Given this list of marker genes Nfatc1, Zfp980, Rnf34, Gsn, Grb2, Mapk14, Kcmf1, Mdh1, Rad51d, Gosr2, Nfat5, Acap2, Elovl2, Taok3, Acat3, Zfp367, Nploc4, Zdhhc17, Rex2, Mex3b, Elovl7, Rev3l, Ppm1d, Luc7l3, Vps50, Pbdc1, Zc3h4, Hoxb1, Cfap97, Ube2b, Prkci, Upp2, Tmtc1, Dram1, Far1, Ctxn1, Nkain2, Zfp513, Dcaf17, Sec61a2, Mnat1, Kras (Kirsten rat sarcoma viral oncogene homolog), Zfp112, Vcpip1, Zbtb34, Pou6f1, Arfgef1, Robo2, Stim1, Osbpl7, Rffl, Rrbp1, Pnpla2, Zfp600, Uchl5, Map2k6, Ark2n (NCBI Gene Id 212163), Scart2, Robo1, Abi1, Ankle2, Ostn, Yeats2, Itm2c, Trem1, Gria3, Ccnk, Snap91, Atf5, Sntg1, Tmem43, Clrn1, Homer1, Epha7 (NCBI Gene Id 13841), Tspoap1, Ctdspl2 (NCBI Gene Id 51895), Rnf139, Msc, Rdx, Zfp981, Mfsd4b1, Dlgap1 (NCBI Gene Id 71192), Crk, Gls2, Osbpl6, Ctbp2, Tmem52b (transmembrane protein 52B), Papolg, Ankrd29, Brdt, Aqp4, Edrf1, Slc14a1, Prl, C8b, Csmd3, Pip5k1c, Wdr72, Hpca, Gpcpd1, Tmem104 (transmembrane protein 104), Ano4, Wdr1, Klhl14, Fam241a, Gsk3b, Mmd, Zbtb11, Mrpl1, Ptgr1, Acat2, Jmjd1c, Herpud2, Tnfrsf22, Dpp10, Rad23b, Sp4, Tesmin, Lipt2, Serp1, Gng7, here is a description of the gene set: species: Mus musculus Genes predicted to be targets of miRBase v22 microRNA mmu_miR_713 in miRDB v6.0 with MirTarget v4 prediction scores > 80 (high confidence targets). from publication Chen Y, Wang X (PMID 31504780) Mouse Gene Set: MIR_713